The following is a description of a gene set: studied in species Homo sapiens Human Gene Set: GSE44649_WT_VS_MIR155_KO_ACTIVATED_CD8_TCELL_UP MicroRNA-155 (miR-155) is upregulated in primary effector CD8 T cells but is expressed at low amounts in naïve cells. Anti-viral CD8 T cell responses and viral clearance were impaired in miR-155 deficient (bic-/-) mice, and this defect was intrinsic to CD8 T cells, as adoptively transferred bic-/- CD8 T cells generated greatly reduced primary and memory responses during infection. To understand the mechanism by which miR-155 regulates CD8 T cell activation, we analyzed the gene expression profiles of naive and in vitro activated wild-type and bic-/- CD8 T cells. from publication Gracias DT, Stelekati E, Hope JL, Boesteanu AC, Doering TA, Norton J, Mueller YM, Fraietta JA, Wherry EJ, Turner M, Katsikis PD (PMID 23603793) Genes up-regulated in activated CD8 T cells: wildtype versus MIR155 knockout., and this is the list of marker genes: SAMSN1, TSPAN3, TSPO, AARS1, ADAM9, VSIG10, SBNO2, PSME1, OGFR, ANAPC2, NLRC5, RELB (NCBI Gene Id 5971), JDP2, CASP4, MYO1C, TLCD1, ISCU, SUSD2, SART1, SSH1, MFHAS1, CDK5R1, SLC4A11, TPST1, ETV3, NFIL3, LGALS3BP, CACNB3, SLTM, TRIP10, PARP9, EHD1, BCL2L11, ZNFX1, TPST2, PPP2R2D, GSC2, VTI1A, NIPAL1, DUSP2, SERPINB9, TAPBP, FZD5, BASP1, SLFN13, RNF114, ATF4, TNFSF9, CCL5, GPBP1, SPATC1L, ELMO3, IFFO2, IRF1, LDLR, EDEM1, PTGER4, GUCD1, LRRK1, MTHFR, RND1, APAF1, ITPKC, GBP7, EVA1B, PLCD3, STOML1, SWAP70, DOK1, F11R, ZBTB10, MRPS7, PPA1, KMT2A, IRF4, IFI35 (NCBI Gene Id 3430), PHLPP1, GK, NAA20, BBX, PLEKHG2, EBI3, SLFN5, TNIP2, FAM114A1, NT5C3A, TAP1, N4BP1, SLAMF1, PTPN2, MLLT6, STAT2, OCIAD1, CD40, PRDM1, CLIC4, FOXP4 (forkhead box P4), TCF25, RFTN1, LAG3, LAMP1, PARP14, IKZF4, IL4I1, ADPRH, RNF40, TMEM19, CACNA1S, DPP3, MDK, CSRNP1, TAP2, AP1G2, SLC4A8, NXF1, CAPN10, EGF, C3orf80, PRMT2, ARFGAP3, LRATD2, LRSAM1, HERC6, CPSF7, RTF2, FBXL18, IFIT3, STARD10, TP53INP2, MED15, XPO6, POGLUT1, ITM2C, TMTC2, ATP6V0A1, PACS2, PLA2G4F, NDST2, GPR4, IL15, ST7, SPTAN1, NDRG1 (N-myc downstream regulated 1), MIF4GD, TNFRSF9, SSUH2, ANXA4, MARCHF5, AGRN, SPSB1, IFRD1 (interferon related developmental regulator 1), CMTR1, GSDMD, WASHC1, MAP3K11, TMEM39A, SBDS, HELZ2, LAD1, MMD, PCP4, POLR3C, CDC42EP3, KTN1, FABP5, CHD7, RGS1, IL1RN, SNN, DHX58, REL, IFI27L2, PRDM4, DDX60, NUDT17, SOCS1, JAK3, GYG1, METRNL, TMEM140, TRAFD1, RILPL2, STXBP6, PSMB10, HTR7, GYPC, TRIOBP, RSAD2, GPD2, FAS (NCBI Gene Id 355), TREX1, IRGM, JAK1, CFLAR, CD83, TMCC3, EPHA1, INTS11, OPRD1